The following is a description of a gene set: species: Mus musculus Any process that decreases the frequency, rate or extent of the chemical reactions and pathways resulting in the metabolism of collagen, any of a group of fibrous proteins of very high tensile strength that form the main component of connective tissue in animals. Mouse Gene Set: GOBP_NEGATIVE_REGULATION_OF_COLLAGEN_METABOLIC_PROCESS, and this is the list of marker genes: Il6, Nr1h4, Emilin1, Il6ra, Ppard, Adora2b, Notch1, Cyp2j6, Rap1a, Errfi1, Rapgef3, Cygb, Cyp7a1, Nppc, Got1, Cst3, Ager, Pparg, Fn1